Given this list of marker genes Opalin, Drd3, Nkx2-2os, Prmt5 (protein arginine N-methyltransferase 5), Dag1, Dicer1, Enpp2 (ectonucleotide pyrophosphatase/phosphodiesterase 2), Sox1, Ctnnb1, Id2, Daam2, Aspa, Tlr2 (toll-like receptor 2), Zfp365, Tenm4, Zfp488, Sirt2, Tnfrsf1b, Notch1, Wdr1, Mtor, Tcf7l2, Hdac1, Mdk, Mir23a, Gsx2, Slc45a3, Id4, Il34, Lingo1 (NCBI Gene Id 235402), Clcn2, Hdac2, Mir219a-2 (NCBI Gene Id 723904), Rheb, Tmem98, Hes1, Hes5, Bmp4, Nf1, Nkx2-2, Ptprz1, Ptn, Trp73, Il33 (NCBI Gene Id 77125), Ptpra, Pparg, Qki, Cxcr4, Dusp15, Dusp10, Tnfrsf21, Nkx6-1, Myrf, Shh (NCBI Gene Id 20423), Olig2, Nkx6-2 (NK6 homeobox 2), Mir219a-1 (microRNA 219a-1), Dlx1, Dlx2, here is a description of the gene set: studied in species Mus musculus Mouse Gene Set: GOBP_REGULATION_OF_OLIGODENDROCYTE_DIFFERENTIATION Any process that modulates the frequency, rate or extent of oligodendrocyte differentiation.